Given this list of marker genes PANK2, SLC1A2, FZR1, CRB1, RLBP1 (retinaldehyde binding protein 1), GTF2H5, BMP4, AHI1, ERCC3, SYNGAP1, POU3F4, RBP3, DALRD3, ALG6, GABBR2, SCAPER, TULP1, HK1, TLCD3B, RDH12, RAB28, RIMS1, FKRP, PRCD, ATP6V1A, CA2, FBN2, NMNAT1, POMT1, SLC38A3, POMGNT1, CYFIP2, DNM1, IFT88, SLC19A2, ARL6, TUB, CDH3, CELF2, PACS2, COL2A1, RS1, AHR, ARL2BP, ELOVL4, ASXL1, TTLL5, FOXG1, NR2E3, SAG, PLK4, GABRB2 (gamma-aminobutyric acid type A receptor subunit beta2), NEK2, CNGA1 (cyclic nucleotide gated channel subunit alpha 1), IFT172, CST3, PRPF6, PITPNM3, MTTP (NCBI Gene Id 4547), CERKL (NCBI Gene Id 394232), AARS1, AP3B2, CNKSR2, KCNB1, PRPF3, CNGA3, PRPF8, VWA8, ARL3, RP2, SEMA4A, SH3BP2, CEP78, BBS4, VCAN, ATP1A3, ERCC2, OPN1MW, PCARE, RHO, LARGE1, RPGR, C9, PDE6B, PNPLA6, PARS2 (NCBI Gene Id 91517), MIR204, CACNA2D1, POC1B, POMK, CP, C1QTNF5, RP1L1, HGSNAT, EPG5, XYLT2, YARS1 (tyrosyl-tRNA synthetase 1), IFT43, XYLT1, CC2D2A, NTRK2, DLAT (NCBI Gene Id 1737, dihydrolipoamide S-acetyltransferase), RGR, INPP5E, APOE, ALDH3A2, HMCN1, MFRP, FBXO28, ARSG, RDH11, KIAA1549, KCNV2, HTRA1, SLC13A5, DRAM2, SLC6A6, ZNF423, EEF1A2, TPP1 (NCBI Gene Id 727719), RPGRIP1, BBS9, PHYH, CTSD, GUCA1A (guanylate cyclase activator 1A), KCNJ13, EYS, MAB21L1, CLRN1, ABCA4, CLN3, ATXN7, SIX6 (NCBI Gene Id 4990), NEK8, MRPL39, IMPG2, MPLKIP, ERCC6, CFHR1, USH2A, BEST1, GNPTAB, TRNT1, ANO10, PISD, TMEM67, TRAK1, FKTN, HLA-A, FGF12, CA4, IDH3A (NCBI Gene Id 3419), PRPH2, EFEMP1, PDE6H, SDCCAG8, KCNA2, CTNNB1, SNRNP200 (small nuclear ribonucleoprotein U5 subunit 200), CYP4V2, ERCC8, FAM161A, ZFYVE26, ATP1A2, PAK2, SZT2 (SZT2 subunit of KICSTOR complex), OPA1, SCN3A, ARHGEF18, TRAF3IP1, CWC27, LMNA, APOB, IDH3B, PRPF31, WWOX, GNAT2, TNFRSF11B, REEP6, IFT140, TTC8, SYNJ1, ALMS1, SUMF1, ZNF513, ADAM9, CACNA1B, AGBL5, PDE6C, YWHAG, KIZ, GNB5, DHX38, UNC119 (NCBI Gene Id 9094), PAX2, CNGB3, ROM1, CFI, MAPKAPK3 (MAPK activated protein kinase 3), UBA5, CLTC, AIPL1, LZTFL1, PDE6G, PDE6A, SLC24A1, MMACHC, CEP164, CFH, GUCY2D, KLHL7, KCNC2, OPN1LW, RPE65, CNGB1, CACNA1F, ASAH1, HCN1, RNF113A, PPT1, MCOLN1, PEX7, CCDC28B, GABRA2, USP45, LIG3, MAK, RDH5, GUCA1B, NRL, RP1, ABCC6, HSD17B10, RP9, CFHR3, SAMD7, COL18A1, TUBB4B, CFAP410, ZNF408, TARS1, CFAP418, NUS1, CACNA2D4, PPP3CA, ACTL6B, SCN1A, CLN6, ATF6, LAMA1, SPATA7, CDK19, SCN8A, STUB1 (STIP1 homology and U-box containing protein 1), CRX, CLCC1, CLN5, GTF2E2, IDUA, IMPDH1, CARS1, FBLN5, P3H2, DHDDS, IMPG1, RBP4, SPG11, MAN2B1, LRAT, FSCN2, PCYT1A, WDR19, CNNM4, LCA5, GRK1, OFD1, POMT2, FBLN1, GBA1 (glucosylceramidase beta 1), GABRG2, RAX2, CDHR1, PROM1 (prominin 1), CACNA1A, TOPORS, NECAP1, MERTK, WRN, TIMP3, BBS1, PRPF4 (NCBI Gene Id 9128), BBS2, SLC7A14, GABRA5, GRIN2D, BBS5, here is a description of the gene set: Retinal degeneration A nonspecific term denoting degeneration of the retinal pigment epithelium and/or retinal photoreceptor cells. Human Gene Set: HP_RETINAL_DEGENERATION studied in species Homo sapiens